The following is a description of a gene set: Human Gene Set: GOBP_ORGANOPHOSPHATE_ESTER_TRANSPORT The directed movement of organophosphate esters into, out of or within a cell, or between cells, by means of some agent such as a transporter or pore. Organophosphate esters are small organic molecules containing phosphate ester bonds. species: Homo sapiens, and this is the list of marker genes: CPTP, OSBPL5, SLC35A2, SLC25A52, ATP8A2, TMEM30A, CALHM2, SLC35A3, SLC25A25, ABCB4, PITPNM3, OSBPL2, ABCC1, VAPA, APOE, XKR9, SCARB2, G6PC3, SLC19A1, ATG9A, SLC25A6, PITPNA (NCBI Gene Id 5306), ANKH, SLC35B2, XKR7, ATP8B1, ATP8B2, XKR6, KCNN4, SPNS1, ANO6, SLC25A32, SLC66A2, SHOC2, MTTP, CALHM4, PRELID1, ETNPPL, ABCB1, CLPTM1L, EPG5, APOC2, CALHM3, LRRC8D, ATG9B, ANO7, ABCA3, PLSCR2, SLC35A4, SLC35C2 (NCBI Gene Id 51006), ABCD1, PITPNM2, SLC25A16, LRRC8B, LRRC8E, SLC37A3, ATP11C, PLSCR4, SLC25A47, VMP1, SLC33A1, SERINC2, NPC2, TMEM63B, ABCD2, ABCC6, TMEM41B, APOC3, PITPNM1, PRELID3B, SLC35B3, ATP11A, PRAP1, ATP10B, SLC17A3, CALHM1, TMEM241, ADCY10, CALHM5, LDLR, ABCC5, PCTP, ATP8A1, ESYT1, SERINC3, OSBPL10, ABCA1, SLC25A5, SLC25A53, PLTP, SLC25A36, SLC37A1, ABCG1, SLC25A42, SLC35D2, TMEM30B, PLSCR3, ATP8B3, GLTPD2, XRCC4, TRPC5, PRELID2 (NCBI Gene Id 153768), SLC35B1, APOA1, SLC37A4, SLC25A33, SLC25A4, SLC44A4, CD47, ABCA7, SLC35A5, PITPNB, TRIAP1, PANX1, C2CD2L, G6PC1, VDAC2 (voltage dependent anion channel 2), SLC35C1, ANO9, SLC46A2, GLTP, CETP, SLC35A1, SLC25A41, ANO4, PLA2G10, PLSCR5, SLC25A51, PLEKHA8P1 (pleckstrin homology domain containing A8 pseudogene 1), FASLG (Fas ligand), PRELID3A, XKR8, CALHM6, SLC17A9, ATP9A, ATP10A, SLC25A24, ATP8B4, SLC35B4, CR1, SLC35D1 (NCBI Gene Id 23169), SLC25A23, OSBPL8, SLC37A2, ABCC4, SLC35E3, ABCA12, ATP11B, APOA2, SCARB1, SLC4A1, SLC25A19, MFSD2A, ABCA4, APOA4, APOC1, ABCC11, SLC25A17, ABCG8, ATP10D, ANO3, SLC25A31, LRRC8C, SCP2, SLC35D3, LRRC8A, BLTP1 (NCBI Gene Id 84162), PLEKHA8, XKR4, ATP9B, PLSCR1, OSBP, PITPNC1, DBI, TNFAIP8L3, P2RX7, SERINC5, CERT1, APOA5